The following is a description of a gene set: studied in species Mus musculus Any process that reduces the extent to which blood vessels can be pervaded by fluid. Mouse Gene Set: GOBP_NEGATIVE_REGULATION_OF_VASCULAR_PERMEABILITY, and this is the list of marker genes: Ifnb1, Ramp2, Slit2, Cldn5, Arhgap35 (Rho GTPase activating protein 35), Fermt2, Pde3a, Ddah1, Angpt1, Pde2a, Tjp1, Ptprj, Amot, Nr3c1, Sh3gl2, Adora2a, Ceacam1, Akap12, Apoe, Abcc8, Vegfa, Adm